The following is a description of a gene set: Cutaneous lesion that develops as a dry, scaly, red patch that evolves to an indurated and hyperpigmented plaque with adherent scale. Scarring may result in central white patches (loss of pigmentation) and skin atrophy. Discoid lupus rash species: Homo sapiens Human Gene Set: HP_DISCOID_LUPUS_RASH, and this is the list of marker genes: SPP1, UBE2L3, IGHG1, TNIP1, KIAA0319L, NCF2, BANK1, C1QB, FCGR2B, ETS1, SAT1, TREX1, HLA-DRB1, TNFAIP3, MECP2, JAZF1, NCF1, PDCD1, STAT4, CR2, BLK, LEMD3, TLR7, ITGAM, C4A, FCGR3B, PTPN22, PXK, TNFSF4, C4B, CTLA4 (NCBI Gene Id 3411), DOCK11, IRAK1, DNASE1, CYBA, CYBB (cytochrome b-245 beta chain), IRF5, C1QC, IL10